The following is a description of a gene set: A protein complex providing a discrete opening in the nuclear envelope of a eukaryotic cell, where the inner and outer nuclear membranes are joined. Mouse Gene Set: GOCC_NUCLEAR_PORE species: Mus musculus, and this is the list of marker genes: Mad2l1, Eif5a, Nup188, Mx1, Chmp7, Nup160, Mcm3ap, Senp2, Pom121, Kpnb1, Nup58, Ranbp17, Nup50, Zc3hc1, Parp11, Nup43, Nup35, Chmp1b, Nup155, Chmp6 (NCBI Gene Id 69715), Eny2, Nup42, Nup93, Xpo4 (NCBI Gene Id 78542), Sec13, Nutf2, Nutf2-ps1, Chmp2a, Mx2, Chmp4c, Nxt1, Ranbp1, Nup214, Ndc1, Nup54, Chmp1a, Ahctf1, Rae1, Nup62, Nup107, Cetn3, Tpr, Ran, Lbr, Chmp1b2, Ube2i, Kpna4, Nup153, Mad1l1, Pcid2, Xpot, Nxf1, Gle1, Nup85, Ranbp2 (NCBI Gene Id 353053), Xpo7, Chmp3, Nup210l, Seh1l, Chmp2b, Nup98, Chmp4b, Chmp5, Nup88, Tnks, Nxt2, Nup37, Vps4b, Rangap1, Pom121l2, Nup62cl (NCBI Gene Id 279706), Cetn2, Bicd2, Aaas, Nup210, Nup205, Nup133, Vps4a